Given this list of marker genes RPP40, ETS2, PXYLP1, JPH1, EIF2S1, RRP15, ZNFX1, CCNB1, STAT4, KRT86, NMD3, NDST1, TRNT1, RAD1, SH2B3, TRIB3, CD55, AUNIP, DCAF4, DNAJA3, IMPA1, JUND, POLR1G, HSPA5, SRPRB, ZNF584, RRM2, IL19, TFAM, MAF, ADO (2-aminoethanethiol dioxygenase), CMPK2, TWF1 (NCBI Gene Id 82712), UTP14A, POLR1E, TPPP2, YDJC (YdjC chitooligosaccharide deacetylase homolog), RABIF, QTRT2, ZNF48, NR4A3, PHF5A, SPRED1, OTUD4, RPF2, SAMSN1, ATF1, BCL2L1, HILPDA, ITPR3, RBM18, LIF, AJAP1, CCND2, TMEM201, ABHD3, SRRT, KIF21B, PITPNA, IDH3A, SEH1L (NCBI Gene Id 81929), SCD, KPNA4, MRPS6, DRG1, PRP4K, SNHG17, ING5, GEMIN6, CCT6A, WDR12, NCL, EML4, STIP1, MSC-AS1, RRAS2, NETO2, COPRS, HIVEP2, TRMT10C, NAB2 (NGFI-A binding protein 2), PUM3, GAR1, RAB18, GUK1, FBXO30, FUT4, NFKBIZ (NFKB inhibitor zeta), NUP58, CCNE1, MFNG, SLBP, IGFLR1, KLF6, E2F6, POLR3K (RNA polymerase III subunit K), ATP8B2, NUDC, PRPF4, NRARP, TWNK, SNRPB2, PTGER3, DDIAS, DHX15, TIMM8A, LTV1, RGS3, NLRP5, TIMM17A, ZNF367, ZDHHC9, DNTTIP2, SRSF10, MTHFD1L, MCRIP2, PHF13, IL2RB, NIP7, REEP3, ZHX1, SRSF7, PNO1, CBFB, PIM3, PPP1R1A, CDC6 (NCBI Gene Id 990), DIMT1, BCL2, NUP153, CDK17, LARP4, GNPNAT1, AIRIM, SNHG1 (small nucleolar RNA host gene 1), ARX, ETV5, TLCD1, PRELID3B, NPM3, PPP1R15B, SLC2A1, TMEM158, DDX39A, GTPBP4, SPRED2, TGFBR1, IRX3, MRTO4, ACTR3, RYBP, SMIM13, TMEM70, FOXN2, BZW1, PJA1, SLAIN2, ZNF330, ERICH1, FOSL1, HSPA1A, RAP1B, TNFRSF12A, TEX10, ATG101, SLC2A3, TXNDC17, PNMA8A, SVIL, ZEB1, PDSS1, CRLF3, DDX19A, IL2RA, TEX30, SDE2, RRS1, BTG3, DUSP6, CCT8, BCCIP, KCTD9, SRSF2, MB21D2, TOX, LRPAP1, GATAD2A (NCBI Gene Id 54815), DUSP2, HNRNPF, SEC24A, LYAR, TIMM13, RSC1A1, FIGNL1, MAPKAPK3, DLX2, DKC1, URB2, SUV39H2, here is a description of the gene set: It has been recently shown that N-ras plays a preferential role in immune cell development and function; specifically: N-ras, but not H-ras or K-ras, could be activated at and signal from the Golgi membrane of immune cells following a low level TCR stimulus. The goal of our studies was to test the hypothesis that N-ras and H-ras played distinct roles in immune cells at the level of the transcriptome. First, we showed via mRNA expression profiling that there were over four hundred genes that were uniquely differentially regulated either by N-ras or H-ras, which provided strong evidence in favor of the hypothesis that N-ras and H-ras have distinct functions in immune cells. We next characterized the genes that were differentially regulated by N-ras in T cells following a low-level TCR stimulus. Of the large pool of candidate genes that were differentially regulated by N-ras downstream of TCR ligation, four genes were verified in qRT-PCR-based validation experiments as being differentially regulated by N-ras (Dntt, Slc9a6, Chst1, and Lars2). Finally, although there was little overlap between individual genes that were regulated by N-ras in unstimulated thymocytes and stimulated CD4+ T-cells, there was a nearly complete correspondence between the signaling pathways that were regulated by N-ras in these two immune cell types. Since we were interested primarily in genes that were differentially regulated by N-ras following a low-level TCR stimulus, our microarray data comparison was between data from TCR-stimulated, WT CD4+ T-cells and from TCR-stimulated, N-ras KO CD4+ T-cells. Genes that were differentially regulated in the comparison between stimulated N-ras KO CD4+ T-cells and unstimulated N-ras KO CD4+ T-cells, as well as those genes that were differentially regulated in the comparison between stimulated WT CD4+ T-cells and unstimulated WT CD4+ T-cells were excluded from this analysis. To determine if N-ras and H-ras regulate different sets of genes in thymocytes, a comparison was made between the set of genes that were differentially regulated by N-ras in the vs. comparison and the set of genes that were differentially regulated by H-ras in the vs. comparison. Genes up-regulated in activated CD4 T cells: NRAS knockout versus wildtype. Human Gene Set: GSE45739_NRAS_KO_VS_WT_ACD3_ACD28_STIM_CD4_TCELL_UP from publication Lynch SJ, Zavadil J, Pellicer A (PMID 23755101) studied in species Homo sapiens